The following is a description of a gene set: Human Gene Set: HP_BODY_ODOR A perceived unpleasant smell given off by the body. Body odor species: Homo sapiens, and this is the list of marker genes: FMO3, ACAT1, GPR101, IVD, DMGDH